The following is a description of a gene set: Human Gene Set: GOMF_11_CIS_RETINAL_BINDING studied in species Homo sapiens Binding to 11-cis retinal, an isomer of retinal that plays an important role in the visual process in most vertebrates. 11-cis retinal combines with opsin in the rods (scotopsin) to form rhodopsin or visual purple. Retinal is one of the three compounds that makes up vitamin A., and this is the list of marker genes: RLBP1, OPN4, ABCA4, OPN3, OPN5, RHO, CYP27C1